The following is a description of a gene set: Human Gene Set: KEGG_MEDICUS_REFERENCE_TLR2_4_MAPK_SIGNALING_PATHWAY TLR2/4-MAPK signaling pathway. Pathway ID: N00438. Pathway type: Reference. Pathway class: nt06517 TLR signaling. Pathway Definition from KEGG: (TLR2,TLR4) -> (TIRAP+MYD88) -> (IRAK4+IRAK1) -> (TRAF6+TAK1+TAB2) -> (MEK,MKK3/6,MKK4/7) -> (ERK,p38,JNK) -> AP1 studied in species Homo sapiens, and this is the list of marker genes: MAPK3, MAPK12, JUN, MAP2K3, TIRAP, TLR4, MAP3K7, MAP2K1, MAPK10, MAPK9, MAPK14, IRAK1, TAB2, MAP2K2, TRAF6, FOS, TLR2, IRAK4, MAPK8, MAPK13, MYD88, MAPK11, MAP2K6, MAP2K4, MAP2K7, MAPK1